Given this list of marker genes DNAAF10, MIR374B, N6AMT1, GPHN, TRBC2, HBB, SLX1B, FCMR, CCNE2, here is a description of the gene set: from publication Hoek KL, Samir P, Howard LM, Niu X, Prasad N, Galassie A, Liu Q, Allos TM, Floyd KA, Guo Y, Shyr Y, Levy SE, Joyce S, Edwards KM, Link AJ (PMID 25706537) species: Homo sapiens Genes up-regulated in monocyte 7d vs 0d in adults after exposure to 2011-2012 trivalent inactivated vaccine (A/California/7/09 (H1N1), A/Perth /16/2009 (H3N2), B/Brisbane/60/2008), time point 7D. Comment: Up-regulated DE RNA transcripts (up >= 1.5x) shared between both TIV-vaccinated donors Systems biology is an approach to comprehensively study complex interactions within a biological system. Most published systems vaccinology studies have utilized whole blood or peripheral blood mononuclear cells (PBMC) to monitor the immune response after vaccination. Because human blood is comprised of multiple hematopoietic cell types, the potential for masking responses of under-represented cell populations is increased when analyzing whole blood or PBMC. To investigate the contribution of individual cell types to the immune response after vaccination, we established a rapid and efficient method to purify human T and B cells, natural killer (NK) cells, myeloid dendritic cells (mDC), monocytes, and neutrophils from fresh venous blood. Purified cells were fractionated and processed in a single day. RNA-Seq and quantitative shotgun proteomics were performed to determine expression profiles for each cell type prior to and after inactivated seasonal influenza vaccination. Our results show that transcriptomic and proteomic profiles generated from purified immune cells differ significantly from PBMC. Differential expression analysis for each immune cell type also shows unique transcriptomic and proteomic expression profiles as well as changing biological networks at early time points after vaccination. This cell type-specific information provides a more comprehensive approach to monitor vaccine responses. Human Gene Set: HOEK_MONOCYTE_2011_2012_TIV_ADULT_7DY_UP